The following is a description of a gene set: from publication Dik WA, Pike-Overzet K, Weerkamp F, de Ridder D, de Haas EF, Baert MR, van der Spek P, Koster EE, Reinders MJ, van Dongen JJ, Langerak AW, Staal FJ (PMID 15928199) studied in species Homo sapiens Human Gene Set: GSE22601_CD4_SINGLE_POSITIVE_VS_CD8_SINGLE_POSITIVE_THYMOCYTE_UP T cells develop from progenitors that migrate from the bone marrow into the thymus. Thymocytes are subdivided roughly as being double negative (DN), double positive (DP), or single positive (SP), based on the expression of the CD4 and CD8 coreceptors. The DN stage is heterogeneous and can be subdivided into four distinct subsets in mice based on the expression of CD44 and CD25. In human, three distinct DN stages can be recognized: a CD34+CD38−CD1a− stage that represents the most immature thymic subset and the consecutive CD34+CD38+CD1a− and CD34+CD38+CD1a+ stages. Human DN thymocytes mature via an immature single positive (ISP CD4+) and a DP stage into CD4+ or CD8+ SP T cells that express functional T cell receptors (TCR) and that exit the thymus. In this study, gene expression was measured in each of these nine stages. Genes up-regulated in single positive thymocytes: CD4 versus CD8., and this is the list of marker genes: IRAK1BP1, GEMIN6, FABP5 (NCBI Gene Id 92424), C9orf40, RGS3, GTF3A, PNP, HLA-DQA1, MRPS35, AMZ2, PCNA, LMF2, EMD, MAPKAPK3, NUDT1, FAM111A, CHCHD5, PAOX, KIF23, PRKRA, CLTA, EEF1G, CSRP2, DYNLL2, TM4SF5, RNF11, PTER, ALKBH7, MAD1L1, UBR7, TAF6L, KMT5C, DAP, RETREG2, SNRPD1, SRGAP3, FAAH, PYCR3, LANCL1, EFCAB11, PQBP1, TRMT2B, ZMYM1, MFSD11, ANAPC7, PAXIP1, CDK10, TDP2, NTAQ1, NEIL3, TSN, XRCC1, MPHOSPH9, RCC2, BANK1, FDFT1, FXN, CENPA, IQCG, ZFP28, S100A10, NMRAL1, SLC29A1, KDM2B, KGD4, MIF4GD, FUT7, BRIP1, RPUSD1 (NCBI Gene Id 64723), DEK, ZMAT1, PLRG1, SUMO3, APRT, DNPH1 (2'-deoxynucleoside 5'-phosphate N-hydrolase 1), CCNE1, CD5, LMNA, CD28, MACO1, NAA38 (NCBI Gene Id 84316), CDC45, CEP72, PDCD4, AHCY, REPS1, ASH2L, SPATA24 (NCBI Gene Id 202051), CIP2A, NFATC2IP, DARS2, JPT1, RAD50 (RAD50 double strand break repair protein), DHFR, CRIP1, RAN, CASP2, SOD1, ADAMTS6, SPDL1, ERGIC3, RDM1, ARRB1, MTBP, SAE1, CD96, RGCC, RAD52, BLOC1S2, NEK2, TBX21 (NCBI Gene Id 30009), ALDOA (aldolase, fructose-bisphosphate A), TRIM24, TENT2, TMEM35B, SNX1, RNASEH2A, WDR90 (WD repeat domain 90), MAN2A1, NANP, ASB2, NUDT9, PTRHD1, CDCA7L, UBC, MSL3, PSMA5, MGST3, TARBP2, POLH, ENTPD1, FILIP1L, PRADC1, MED9 (mediator complex subunit 9), CUL7, FKBP2, MRPL45, DNAJB4, ATP5F1B, C11orf54, NUP160, KHSRP, CDKN1A, CDC5L, RABGEF1, PHLDA1, FEN1, HJURP, KIFC1, GRK5, PRELID3B, GTSE1, CCDC77, SRPK1, SLC25A24, SEPTIN10, PTP4A3, CDC27, CPD, RFTN2, HERC3, NEK8, MED23, FANCI, TRIM59, SSR3 (NCBI Gene Id 6747), HSPD1, TTC8, CNIH4, TPGS2, KPNA2, PRIMPOL (primase and DNA directed polymerase), MBD4, ACP1, AMFR, ANP32E, R3HCC1, DCTPP1, CD320, BRD9 (NCBI Gene Id 65980), SLC36A4, STRADB, MAPRE2, RHOB, TUBA1B, SOAT2, B3GLCT, MTMR14, TAX1BP3, NELFCD, IL18 (NCBI Gene Id 3606), UNC93B1, WDHD1, NPM1, RTN3, MYO18A, PIGU, NCAPD2, PDZD11, ZBTB22 (zinc finger and BTB domain containing 22)